The following is a description of a gene set: species: Homo sapiens Catalysis of the transfer of a palmitoyl (CH3-14-CO-) group to an acceptor molecule. Human Gene Set: GOMF_PALMITOYLTRANSFERASE_ACTIVITY, and this is the list of marker genes: ZDHHC20, CPT2, ZDHHC6, ZDHHC14, ZDHHC8, ZDHHC21, ZDHHC5, CPT1A, ZDHHC12, CPT1C, ZDHHC1, SPTLC1, SPTSSB, ZDHHC17, SPTSSA, ZDHHC23, ZDHHC4, ZDHHC24, LRAT, ZDHHC9, SPTLC3, YKT6, ZDHHC7, ZDHHC11B, HHAT (NCBI Gene Id 55733), ZDHHC13, ZDHHC16, ZDHHC19, ZDHHC3, CPT1B, ZDHHC18, SPTLC2, GLUL, ZDHHC11, ZDHHC15, ZDHHC22, ZDHHC2